The following is a description of a gene set: from publication Cui A, Huang T, Li S, Ma A, Pérez JL, Sander C, Keskin DB, Wu CJ, Fraenkel E, Hacohen N (PMID 38057668) Cytokines mediate cell-cell communication in the immune system and represent important therapeutic targets. A myriad of studies have highlighted their central role in immune function, yet we lack a global view of the cellular responses of each immune cell type to each cytokine. To address this gap, the authors created the Immune Dictionary, a compendium of single-cell transcriptomic profiles of more than 17 immune cell types in response to each of 86 cytokines (>1,400 cytokine-cell type combinations) in mouse lymph nodes in vivo. A cytokine-centric view of the dictionary revealed that most cytokines induce highly cell-type-specific responses. For example, the inflammatory cytokine interleukin-1β induces distinct gene programmes in almost every cell type. A cell-type-centric view of the dictionary identified more than 66 cytokine-driven cellular polarization states across immune cell types, including previously uncharacterized states such as an interleukin-18-induced polyfunctional natural killer cell state. Mouse Gene Set: CUI_T_CELL_CD4_TWEAK_RESPONSE_DN Genes negatively differentially expressed in cell type: CD4+ T cell upon treatment with cytokine: TWEAK in mouse lymph nodes in vivo. species: Mus musculus, and this is the list of marker genes: Fos, Klf6, Hspa1a, Junb, Zfp36l2, Jun, Hspa1b